The following is a description of a gene set: studied in species Mus musculus An immune response against bacteria mediated through a body fluid. Examples of this process are the antibacterial humoral responses in Mus musculus and Drosophila melanogaster. Mouse Gene Set: GOBP_ANTIBACTERIAL_HUMORAL_RESPONSE, and this is the list of marker genes: Defa30, Igha, Vip, Defa25, Ighe, H2bc21, Ighm, Defa22, Rpl39, Defb37, Ang, Defa41, Adm, Wfdc21, Klk7, Defa20, Rnase6, Pla2g1b, Tac1, Defa23, Wfdc15a, Ang6, Evpl, Wfdc15b, Defa26, Ppl, Ang5, Ivl, Wfdc13, Wfdc10, Ighg1, AY761185, Bpifa1, Defa42 (NCBI Gene Id 665927), Fga, Ighg2b, Ltf, Ighg3, Defa17, Bpifa5, Wfdc3, Defb1, B2m, Ang4, Npy, Trf, Dmbt1, Defa34, Ang2, Fau, Wfdc2, Mmp7, Rnase4 (ribonuclease, RNase A family 4), Defa37, Bpi, Wfdc5, Lgals4, Wfdc11, H2-T23, Pla2g6, Wfdc12, Defa5, Wfdc18 (NCBI Gene Id 14038), Sprr2a1, Defa35, Defa39, App, Inhca, Slpi, Wfdc16, Klk5, Ctsg, Spag11a, Defa21, Pgc, Defa28, Wap, Defa38, Wfdc17, H2bc12, Defa24, Jchain, Fgb, Nod2, Defa2, Wfdc9, Defa31, Camp (cathelicidin antimicrobial peptide), Defa40, Ighg2c, Defa3, Spon2, Elane, Defa29